The following is a description of a gene set: studied in species Homo sapiens Genes predicted to be targets of miRBase v22 microRNA hsa-miR-6892-5p in miRDB v6.0 with MirTarget v4 prediction scores > 80 (high confidence targets). from publication Chen Y, Wang X (PMID 31504780) Human Gene Set: MIR6892_5P, and this is the list of marker genes: ARL15, SRSF3, GAGE1, HERC3, ST6GALNAC3, ARID4B (NCBI Gene Id 88087), ZNF559-ZNF177, TGFB2, TTR, TNFRSF11B, PROX1, ZNF592, RSBN1, CEBPD, MFAP3L, GPC6, ERC2, DPP10, SLC12A8, ZFHX3, CASC3, CORO2B, LRRC10B, ABCG2, GABRE, DNHD1, CITED2, DNAJC25, RNF213, RCC2, C1orf50, PRKAA2, METTL4, LRP6, ANXA2R, COPS2, NFIB, DUSP11, KATNAL1, ZIC4, SGO1, ZNF24, MED13L, MTMR11, BTN1A1, SBSPON, F2RL2, KLHL6, HSPE1-MOB4, AFAP1L1, KCNB1, CYLD, SRBD1, U2SURP, DTX3L, ARPC5, TRA2A, ANKS6, CCDC59, ZNF302, COX19, ANOS1, DPY19L2, GDNF, DEFB129, CSRNP2, CREB3L2, MOB4, ITGB1BP2, GABBR1, ELMO1, ZNF181, FBXO30, SMG1, SMARCA5, CELSR3, MAP3K2, PIP4P1, FDXACB1, ETV3, DDX59, ANXA9, FUT9, RGMA, SSR1, NPAT, ZNF500, CTNND1, ZNF572, VPS45, FAM161A